Given this list of marker genes ANKRD22, LTV1, ABHD5, BST1, ZSCAN20, TOMM6, TMEM185A, KIF26A, XYLB, RABEP1, CKS1B, UBE2V1, SMAD6, RFNG, PRELID2, SQOR, DTWD2, NOC4L, UBE2H, DDX1, PLPP1, RARS1, GRAP2, FZD4, FOXJ3, SMPD4, ACAT1, CD14, TNFRSF12A, DCAKD, TRIM68, MAPDA, ABCB6, ATP6V1H, DDT, PRKCI, MFSD2A, XRCC6, EDEM1 (NCBI Gene Id 9695), DSEL, HDAC10, ZC3H13, TRIM3, AKAP1, PFKFB4, CLEC5A, ACOT11, MON1A, DHX16 (NCBI Gene Id 8449), NLN, PTDSS1, POP1, PITPNB, PPIL1, TFDP1 (NCBI Gene Id 7027), ASNSD1, DIAPH2, TREM1, NUP85, ATG16L2, ATP6V0A1, TBRG4, CMTM7, KAT7, RPS23, TXNDC17, CAP1, PXMP2, SLIT2, CCDC91, R3HCC1, RPUSD2, PCYOX1, NEK6, FAM8A1, FPR1, SNX22, GLUD1, SLC2A9, HELB, B4GALNT4, B3GALT6, ITGAM, TMEM238, AP4M1, CAMK2G, TTC7B, PTH1R, GFM1, OXCT1, ITGA8, A4GALT, RCBTB1, GXYLT1, RNF128, RNASE10, SLC16A10, ZBTB48, VPS8, UNC119B, METTL6, COPS7A, MCUB, GCHFR, MRPL21 (mitochondrial ribosomal protein L21), LRRC14, FAM120A, TWNK, P4HB, PDXK, GDA, PSMA7, CHAF1B, CEP78, ENC1, CELF4, RBMS2, HCAR2, SPATA2, RNF39, FPR2, RANBP1, DNAAF2, YBX1, PFKFB1, CHCHD1, PEPD, TSR1, PPARGC1B, NVL, BMF, TUBB6, CNKSR3, SLC25A13, CD44, PKP4, MTHFD2L, FAM217B, MLYCD, TRAF3IP1, CDKL2, ALDOC, MRPL36, UTP6, NOB1, SACS, USP36, TLE6 (NCBI Gene Id 84846), FTSJ3, ANKRD10, PDE1A, SNAPC5, ENPP1, FABP5, POLD2, CRTC3, RFK, PREB, TNIP1, CDC25C, GEMIN4, MCOLN1, ATP13A3, TARS1, EMC10, ZDHHC20 (NCBI Gene Id 353177), BCL2L12, MIS18BP1, ARHGAP21, KATNB1, GGACT, LMNB2, DMXL2, PLPP6, PCID2, RPS19, SBF1, TSG101, SCFD2, QPCT (glutaminyl-peptide cyclotransferase), TBC1D25, SMC3, HOXA11-AS, PRPSAP1, TM2D2, SMOX, UBD, SLC39A14, SYT4, DDX31, MEGF9, SF3A1, ACO1, SMIM7, GPR84, MKKS, NCDN, MFSD1, MAD2L1BP (NCBI Gene Id 9587), PPHLN1, here is a description of the gene set: from publication Kaji T, Ishige A, Hikida M, Taka J, Hijikata A, Kubo M, Nagashima T, Takahashi Y, Kurosaki T, Okada M, Ohara O, Rajewsky K, Takemori T (PMID 23027924) Bcl6 germline deletion causes a prominent inflammatory disease, owing to over-expression of Th2 cytokines, and affects the properties of B cells prior to immunization. Therefore we established the B cell-specific Bcl6 deletion mice and analyze the gene expression of naive B cells under physiological conditions. studied in species Homo sapiens Genes down-regulated in marginal zone B lymphocytes with knockout of BCL6: heterozygous versus homozygous. Human Gene Set: GSE28737_BCL6_HET_VS_BCL6_KO_MARGINAL_ZONE_BCELL_DN